The following is a description of a gene set: species: Mus musculus Any process that stops, prevents or reduces the frequency, rate or extent of dendritic spine maintenance. Mouse Gene Set: GOBP_NEGATIVE_REGULATION_OF_DENDRITIC_SPINE_MAINTENANCE, and this is the list of marker genes: Cfl1, Grin2b, Prnp, Fyn, Apoe